The following is a description of a gene set: Human Gene Set: HP_NEUROPATHIC_ARTHROPATHY studied in species Homo sapiens Neuropathic arthropathy, and this is the list of marker genes: ELP1, NTRK1, SPTLC2, ATL3, ATL1, SPTLC1